Given this list of marker genes DCT, DTNBP1, PMEL, ABCB6, TYRP1, CANX, GPNMB, OCA2, GPR143, RAB7A, TPCN2, TYR, BACE2, RAB27A, CTNS, RAB38, ATP7A, RAB32 (NCBI Gene Id 10981), TH, MLANA, MFSD12, MREG, SLC45A2, here is a description of the gene set: An intracellular membrane-bounded particle found in fungi and containing chitin synthase; it synthesizes chitin microfibrils. Chitin synthase activity exists in chitosomes and they are proposed to act as a reservoir for regulated transport of chitin synthase enzymes to the division septum. Human Gene Set: GOCC_CHITOSOME species: Homo sapiens